Given this list of marker genes Cd63, Lims2 (NCBI Gene Id 225341), Itgb1bp1, Emp2, Nid1, Lamc1, Lama1 (NCBI Gene Id 16772), Flna, Lamb2, Pcsk5, Ctnna1, Lypd10, Lama2, Timp1, Loxl3, Lypd11, Dab2, Cd177, Lamb1, Slc2a10, Lims1, Phactr4, here is a description of the gene set: species: Mus musculus Mouse Gene Set: GOBP_REGULATION_OF_INTEGRIN_MEDIATED_SIGNALING_PATHWAY Any process that modulates the frequency, rate or extent of integrin-mediated signaling pathway.